Given this list of marker genes IPO4, DNAAF4, RABEP1, FAM163A, ACP5, CALHM6, GK, CIAO1, FRMD4A (FERM domain containing 4A), MACROH2A1, PRSS12, MRPL47, TAMM41, GJB4, C19orf48P, ACACA, RGCC, PGLS, SLC35G1, GOLGA3, SMURF2, TIGAR, TFRC, BLTP2, KAT2A, CISD1, THEMIS, PDE3B, CNDP2 (carnosine dipeptidase 2), NOP10, CYP2U1, MRPL38, APPL2, CD300C, ZNF414, FGA, ZC3H8, PRF1, UBAC2, HBG2, TEX15, DOCK10, N6AMT1, XRCC5, ATP1A1, TMEM107, CHCHD3, CTSW, MAPK8, MSTO1, ARMCX2, KICS2, BRD10, STRN4 (striatin 4), TUBD1 (tubulin delta 1), PTH1R, SGK1, PPP3CC, ORC5, RBMXL1, ZYX, KEAP1, CST7, ITK, PDE2A, TMEM141, NHEJ1, GGT1, PUS3, CCNJ, SRFBP1, ORC6, TCP1, EZR, OSTF1, EIF3M, ALG8, RPL4, ILKAP, KLRD1, HDAC2, TRDMT1, DNAAF5, UBE2U (NCBI Gene Id 148581), SMAP2, DRC1, NOB1, SLC16A5, GSTCD, SNED1, ATP8B4, CHAMP1, MTG1, CA12, SLC17A9, NARS1, NUDT6, KREMEN1, RPS16, USE1, ZBED4, EXTL2, RRP12, PDXP, CEACAM20, TRIM13, DCAKD, METTL13 (NCBI Gene Id 88158), PDE12, NOP56, UCHL5, XKRX, RPL26, EIF3L, FRRS1, AMELX, CHD8, IMP3, RPS9, TREML4, ARL3, SCAP, CDC14B, DENND2D (DENN domain containing 2D), TMEM108, RASA2, GARRE1, TAF4B, TUBGCP2, FARSB, GRWD1, AMN, IGLC7, B4GALNT1, WASHC3, POLR3E, HSPBP1, SLC6A19, QDPR, IGFBP7, WDR74, GNMT, CLNS1A, DHODH, FAM241A, UPP2, ELAC2, PWP2, YEATS2, TUBA4A, ABCE1, RTCB, ACSS1, TRIM32, SNX15, RABGGTA, ARL4C (NCBI Gene Id 10123), PANK4, THUMPD1, AFDN, RARA, UTP4, SULF1, SMU1, PNPLA1, LRRC14, SELENOH, KIZ, LSM7, CLEC1A, PRKCB, ZNF341, TUBB, MTERF2, MRM1, DUSP22, BAIAP3, SLC25A4, DYNC1I1, MRRF, MIF, PRXL2C, SKIC3, TLE4, MCM3, NUP93, EIF3E, CP, PPP1R37, MECR, CHST11, RPS7, STX2, ELMO2, CCDC91, NFS1, PKP4, CTDSPL2, ACER1, here is a description of the gene set: from publication Konuma T, Nakamura S, Miyagi S, Negishi M, Chiba T, Oguro H, Yuan J, Mochizuki-Kashio M, Ichikawa H, Miyoshi H, Vidal M, Iwama A (PMID 21540074) species: Homo sapiens Genes down-regulated in comparison of CD4 T cells versus CD8 T cells. Human Gene Set: GSE27786_CD4_VS_CD8_TCELL_DN Each fraction of mouse hematopoietic cells was purified by cell sorting from bone marrow of 8-week-old C57BL/6 mice, and its gene expression was analyzed.